The following is a description of a gene set: Human Gene Set: HP_ALVEOLAR_RHABDOMYOSARCOMA studied in species Homo sapiens Alveolar rhabdomyosarcoma, and this is the list of marker genes: FOXO1, KEAP1, DICER1, PAX3, PAX7